Given this list of marker genes Spib, Abca1 (ATP-binding cassette, sub-family A member 1), Cyp2f2, Anxa8, Saa3, Cd74, Slc29a1, Lbp (NCBI Gene Id 16803), Cp, Ccl9, Sema3c, Wnt6, Taf1d, Rhox5, Col6a1, Hsd11b1, Isyna1, Has2, Sod3, Socs3, Cd9, Igfbp4 (insulin-like growth factor binding protein 4), Lcn2, Ghr, Ero1a, Fas, Ifitm1, Rgs2, Ogn, Rbp1, Pltp, Slc10a6, C3, Col6a2, Enpp2, Cd14, Map4k3, Ahr, Pfkp, Lifr, Gdf10, here is a description of the gene set: species: Mus musculus The c-Jun N-terminal kinases (JNKs) are encoded by three genes that yield 10 isoforms through alternative mRNA splicing. The roles of each JNK isoform in the many putative biological responses where the JNK pathway is activated are still unclear. To examine the cellular responses mediated by different JNK isoforms, gain-of-function JNK1 polypeptides were generated by fusing the upstream mitogen-activated protein kinase kinase, MKK7, with p46JNK1alpha or p46JNK1beta. The MKK7-JNK fusion proteins, which exhibited constitutive activity in 293T cells, were stably expressed in Swiss 3T3 fibroblasts using retrovirus-mediated gene transfer. Swiss 3T3 cells expressing either of the MKK7-JNK polypeptides were equally sensitized to induction of cell death following serum withdrawal. To search for other cellular responses that may be selectively regulated by the JNK1 isoforms, the gene expression profiles of Swiss 3T3 cells expressing MKK7-JNK1alpha or MKK7-JNK1beta were compared with empty vector-transfected control cells. Affymetrix Genechips identified genes for which expression was increased in MKK7-JNK-expressing cells relative to vector control cells. Twenty genes including those for c-Jun, MKP-7, interluekin-1 receptor family member ST2L/ST2, and c-Jun-binding protein were induced similarly by MKK7-JNK1alpha and MKK7-JNK1beta proteins, whereas genes were selectively increased by MKK7-JNK1alpha and genes were selectively increased by MKK7-JNK1beta. The set of genes selectively induced by MKK7-JNK1beta included a number of known interferon-stimulated genes (ISG12, ISG15, IGTP, and GTPI). Consistent with these gene expression changes, Swiss 3T3 cells expressing MKK7-JNK1beta exhibited increased resistance to vesicular stomatitis virus-induced cell death. These findings reveal evidence for JNK isoform-selective gene regulation and support a role for distinct JNK isoforms in specific cellular responses. from publication Han SY, Kim SH, Heasley LE (PMID 12354774) Mouse Gene Set: HAN_JNK_SINGALING_DN Genes down-regulated in 3T3 cells (fibroblast) upon activation of JNK pathway.